Given this list of marker genes RAB7A, TREX1, ATG2A, NPR2, RNASEK, CHMP2B, CREG1, ATG2B, PINK1, LAMP2, ATG4D, RAB23 (RAB23, member RAS oncogene family), ARSG, VPS54, WDR45, VPS4A, RUFY4, RAB20, EPM2A, UBXN2A, MBTPS1, ULK3, AP3B1, P2RX7, MAP1LC3C, ATG101, NDP, ATP10B, MYO7A, ATG4A, TMEM63A, TMEM9, RETREG2, ATF2, TMEM106B, GABARAPL3, ATG9B, GAA, ATP6AP1, ATP2A2, EFNB1, ZKSCAN3, RAB33B (NCBI Gene Id 83452), CHMP1B, CLN5, PIK3C3, ATG4C, PLA2G5, ATG12, RALB, CLN8, IFT20, TMEM41B, SNX18, VPS35, NSFL1C, CHMP5, FNIP1, ATP6V0B, ARFIP2, ATP6V0A1, EHMT2, ATP6AP2, TBC1D14, RAB1A, ZFYVE26, IRGM, MAP1LC3B2, UBQLN2, CCDC115, CORO1A, MOAP1, ARSB, SNX30, CLVS2, ATG10, ATG5, MTMR3, CHMP1A, RAB1B, GBA1, CHMP6, ATP6V1A, PIKFYVE, MAP1LC3B, MFSD8, MFN2, RAB34, SEC22B, ARL8B, TASL, C9orf72, GRN, WASHC5, BAG3, FLCN, ELAVL1 (ELAV like RNA binding protein 1), SCFD1, TP53INP2, ANXA2, PIK3C2B, ATG16L2, TFE3, IFT88, RAB43, ULK2, PIP4K2A, AP4M1, OCA2, CHMP4A, SNAPIN, MCOLN1, STX12, HPS1, RAB3GAP2, SCARB2, TOM1, ATG4B, CHMP4C, TCIRG1, TMEM39A, BECN2, RETREG3, GABARAPL2, VPS16, NUPR1, RAB14, DNAJC16, ATP6V1D, PIP4K2B, EPHB2, CHMP7, NAGPA, WIPI1, SPG11, HEXB, RAB39A, ACP2, HPS4, SNX7, VPS18, AMBRA1, RAB33A, SNX4, CTSD, IRGQ, CLVS1, FHIP1B, RNF186, GNPTAB, STX17, ATG16L1, CLN3, MTOR, TRIM32, ATP13A2, LIPA, STING1, TMEM165, VPS11, LYSET, HOOK1, CHMP4B, ATG14, B4GALNT1, VPS4B, MTM1, LRRK2, MAN2A1, VIPAS39, LRBA, SMURF1, VPS33B, RAB7B, HOOK3, ATG3, SYT7, PPT1, SLC45A2, EMC6, PACS2, CHMP3, ELAPOR1, CHMP2A, AKTIP, TPCN2, CHEK2, HOOK2, PI4KB, ATG7, RAB5A, TBC1D12, UBQLN1, PIP4K2C, TPP1, ATG13, PSEN1, HID1, ATP6V1F, LAMTOR1, EXT1, NAGLU, GABARAPL1, BECN1, ABCA1 (NCBI Gene Id 8371), ATG9A, LAMP1, RAB3GAP1, FIG4, TRAF6, MAP1LC3A, UBXN2B, ATP6V1H, WIPI2, PHF23, LAPTM5, TFEB (transcription factor EB), STBD1, LAPTM4B, TP53INP1, CLN6, TMEM175, HSD17B1, AP5Z1, RAB1C, SH3GLB1, VPS33A, RETREG1, LRSAM1, FEZ2, ULK1, RAB19, WDR45B, BNIP3, RNF5, SPNS1, ATP6V0C, GABARAP, FEZ1, SRPX (NCBI Gene Id 8406), SMCR8, TMEM199, RB1CC1, ATM, HEXA, PPP3CB (NCBI Gene Id 5532), VMP1 (NCBI Gene Id 81671), here is a description of the gene set: species: Homo sapiens Human Gene Set: GOBP_VACUOLE_ORGANIZATION A process that is carried out at the cellular level which results in the assembly, arrangement of constituent parts, or disassembly of a vacuole.